The following is a description of a gene set: species: Mus musculus The process in which the developmental fate of a cell becomes restricted such that it will develop into a neuron. Mouse Gene Set: GOBP_NEURON_FATE_COMMITMENT, and this is the list of marker genes: Sox9, Gata2, Nkx6-1, Ctnnb1, Gli3, Hoxd10, Tfap2c, Lbx1, Rbpj, Ascl1, Foxa2, Tbr1, Shh, Casz1, Zdhhc16, Prox1, Smarcc2, Otx2, Atoh1, Gbx1, Wnt1, Pax3, Epop, Lhx3, Eya1, Hoxc10, Isl2, Ntrk3 (neurotrophic tyrosine kinase, receptor, type 3), Nfia, Nkx6-2, Tbx1, Smad4, Foxa1, Isl1, Dll4, Olig2, Lhx6, Nkx2-2, Fkbp8, Zfp521, Dlx2, Nrg1, Nfib, Tgfbr1, Ptf1a, Tlx3, Gsx1, Nkx2-1, Esrp1, Fev, Notch1, Olig1, Prrx1, Bmp4, Pou4f1, Atoh7, Chrd, Evx1, Arx, Six1, Gsx2, Sox2, Pax7, Nfix, Fezf2, Sufu, Tfap4, Notch3 (notch 3), Dlx1, Jag2, Cdc42, Myt1l, Dbx1, Runx1, Dmrt3, Olig3, Pou3f2, Tgfb2, Foxg1, Sox1, Pax6, Ihh, Gli2, Lmo4, Bcl11b, Tunar, Dmrta2, Dll1, Mnx1, Foxn4, Id2, Ehmt2